Given this list of marker genes MT-ATP6, XPR1, HLA-DQB1, EOGT, NDUFB11, PRKAR1A, XPA, AQP5, BANF1, IL17RA, NR3C1, RIN2, ZNF408 (zinc finger protein 408), CSTA, ERCC6, TBL1XR1, BLOC1S5, C2, BLOC1S3, BTNL2, EPHB4, FIP1L1, ARX, NAGA, CASP10, TGM1, DHCR7, NBEAL2, GNE, HEATR3, ITGB3, PTPN22 (NCBI Gene Id 5779), CREB3L1, LOX, TNFRSF1B, TFR2, TYMS, MT-ND5, HCK, MCFD2, FGG, SMC1A, TNFSF11, SLC39A13, GJA8, ITGB4, FRG1, F8, FANCA, NEU1, ALOXE3, COL1A2, MRAS, GNB2, MBTPS2, PIGW, LZTR1, NABP1, PRF1, HCCS, IL36RN, ANKRD26, PARN, DKC1, TET2, F12, CD28, KRT10, STAT3, ATRX, AGA, TTI1, RAB27A, PDGFB, PPP1R15B, TGM5, WRN, SLC2A10, IL12RB1 (interleukin 12 receptor subunit beta 1), ARL6IP6, STAT5B (signal transducer and activator of transcription 5B), BMS1, AGXT, UNC13D, ORAI1, FOXE3, CBL, MEFV, PEPD, MT-ND2, PIGY (phosphatidylinositol glycan anchor biosynthesis class Y), RTEL1, KIT, GP1BA, CLEC7A, GFI1B, TCF4, SPIB, SMAD2, SH2B3, RASGRP2 (NCBI Gene Id 10235), PLOD3, COL5A2, SDHB, RPS6KA3, HPS4, RNASEH2A, ARVCF, CBS, TPM4, F5, ENG, DIAPH1, NRAS, STX11, PIK3R1, ALDH18A1, MT-TW, RNASEH2C, ARHGAP31, CIB1, CDKN1B, FKBP14, SETX, ADAR, HLA-B, TBK1, PRDM16, SUPT16H, TGFBR1, PRKG1, F13A1, IL7, ALDH3A2, PRKACG, GATA2, POLD1, MRE11 (MRE11 homolog, double strand break repair nuclease), WIPF1, ERCC2, MMEL1, LRP1, MAT2A, GABRD (gamma-aminobutyric acid type A receptor subunit delta), THSD4, ATP7A, STXBP2, KDSR, PEX6, RRAS, FECH, SMC3, IL12A, MT-TS2, MPL, CR2, ADGRE2, RECQL4, PLG, TCIRG1, RARA, KCNAB2, RECQL, SAMHD1, HPS5, F7, XRCC4, FERMT3, NLRP3, PDE11A, COL5A1, ETV6, ENPP1, ADAMTS2, PTPRJ (protein tyrosine phosphatase receptor type J), MASP1, MVK, BMPR2, FANCE, PIGO, DNASE1L3, RERE, MST1, PERP, RNF168, RHOH, IFNG, VPS53 (NCBI Gene Id 55275), DCLRE1B, ETHE1, BCOR, PYCR1, GPR35, RAF1, USP8, NHP2, C1R, NFKB1, WAS, PCNA, ZBTB16 (NCBI Gene Id 8070), NAXD, B3GALT6, BRAF, PGAP2, FUCA1, GP1BB, RRAS2, COG4, CFHR1, DLL4, CHST14, ODC1, F9 (coagulation factor IX), COL1A1, ICOS, FANCC, UBA2, GLUL, RUNX1, CCM2, RAD21, ERCC4, TNFSF15, SLC29A3, PIGV, ARMC5, POLA1, NLRP12, FGB, DSE, FGA, MT-ND4, ITGA2B, ADAM17, HPS3, PML, PTDSS1, NLRC4, AEBP1 (AE binding protein 1), COG8, HLA-DPB1, NUMA1, WNT10A, TMC8, MT-ND1, GJB3, SEC24C, OCLN, LMAN1, HBA1 (NCBI Gene Id 3039), SAMD9, LUZP1, SRSF2, GUCY1A1, USF3, IARS2, CAVIN1, UVSSA, GNA11, HS3ST6, AIP, TSPAN12, LMNA, GJB4, DPP9 (NCBI Gene Id 91039), FAS, LBR, TMC6, ANTXR1, PGM3, HPS1, IRF5, KRT2 (NCBI Gene Id 3849), NDP, TNFSF12, ELN, GLB1, MAP2K1, SOX18, LYST, IKZF1, LSM11, ARID1B, ACP5, F10, HEY2, TGFBR2, ARPC4, HOXA11, STING1 (stimulator of interferon response cGAMP interactor 1), POLR3A (RNA polymerase III subunit A), THBS2, MT-ND6, CFH, POU2AF1, SLURP1, SDHC, SERPINF2, SOS1, MYOF, GJA5, RBPJ, MT-CO1, GLA, RAC2, MTAP, DSP, SLC27A4, LORICRIN, TRPM4, NOD2, FLNA, CDH23, LCP2, TBXA2R, IFIH1, GNAS, KRAS, ZNF469, KIAA0319L, MT-CO2, JAK2 (Janus kinase 2), PRKACA, CARMIL2, POLE, TALDO1, RASA1, SASH1, BMP2, C1QB (NCBI Gene Id 713), CYLD, H4C3, AGPAT2, ATM, CTNNB1, MYH11, STAG1, NBN, PDPN, MYH9, PSMB8, NFIA, KRIT1, ANGPT1, EFEMP1, DOCK6, USP18, IPO8, C1S, SLC25A24, DDX11, VWF, ERCC3 (ERCC excision repair 3, TFIIH core complex helicase subunit), BSCL2, SPRED2, GGCX, HBA2, DPM1, ALOX12B, SCN11A, RNASEH2B, LRP5, TBX1, ATR, TERT, UBE4B, TNFRSF1A, TGFB2, PSMG2, SERPINE1, ACVRL1, NSDHL, PLAU, GP9, SLC37A4, SERPING1, MT-ND4L, ELOVL4, CAV1, PRDM5, POLH, STIM1, GJA1, TAF6, FLT4, GATA1, COL7A1, GNAQ, TNXB (tenascin XB), APOLD1, SLC39A4, WRAP53, MMP23B, MANBA, CASZ1, BRD4, UFD1 (NCBI Gene Id 7353), ANTXR2, PIK3CA (NCBI Gene Id 5290), MT-CO3, MT-TQ, VEGFC, KCNQ2, XPC, AP1S1, IL17F, TNPO3, LMX1B, NPM1, IRF2BP2, EGFR, APOE (NCBI Gene Id 99), XPNPEP2, HIRA, STXBP1, NDUFS2, CPN1, GSN, MYD88, TRAF3IP2, F13B, DDR2, JAM2, KLLN, CTSB, KLK11, SULT2B1, PLOD1, MT-CYB, CCN2, CD109, NF1, NSUN2, IKBKG, PPARG, GIMAP5, PGAP3, RNF213, ATP6V1E1, FCGR2C, SCARB2, ANAPC1, LIG4, MAPK1, COL3A1, SIK3, COX7B, PNKP (polynucleotide kinase 3'-phosphatase), SMAD3, ATP6V0A2, MYLK, PIGL, SPINK5, SOS2, KNG1, SDHD, AKT1, SYK, SEC23B, RREB1, FASLG, FYB1, DDB2, DST, MT-TF, BLM, TNFRSF13B, SLFN14, PROS1, DTNBP1, CD19, SREBF1, GDF2, SLC51A, SEMA4D, FTO, SKI, P2RY12, RASA2 (NCBI Gene Id 5922), HDAC8, TREX1, FBN1, PORCN, ACTA2, LIPN, PTPN11, FOSL2, PDGFRB, PRKCZ, FANCD2, CTSA, LEMD2, TGFB3, TP53, MT-TH, GBA1, ITGA3, CD81, ATP7B, MYORG, GNA14, F2, PLEC, BGN, TRPV3 (transient receptor potential cation channel subfamily V member 3), FOS, ELMO2, KRT83, NFIX, KRT1, ASXL1, PDSS1, NOTCH1, ZMPSTE24, CTC1, PRTN3, SLC20A2, SF3B4, FZD4, ABCC6, C4A, DNAJC30, ABL1, SCN10A, DSG4, IL17RC, GNPTAB, USP48, LIG1, TERC (NCBI Gene Id 7012), RNF113A (NCBI Gene Id 7737), HFE, ATP2C1, RIT1, MT-TL1, EPHB2 (EPH receptor B2), SETD2, HLA-DRB1, CALR, SBDS, HLA-DPA1, MS4A1, FERMT1, LYZ, PLCG1, JMJD1C, NTRK1, GCGR, HPGD, SLC35A1, PDCD10, NIPBL, ABCC9, STN1, RNU7-1, CLCN7 (chloride voltage-gated channel 7), SPEN, ARPC1B, G6PC3, COMT, ADA2, MFAP5 (NCBI Gene Id 8076), KDM1A, LARP7, CTLA4, CCR6, KRT5, NFKB2, HPS6 (NCBI Gene Id 95477), CBLB, CAST (calpastatin), ITGA2, SMAD4, TNFRSF13C, SCN9A, UBAP2L, ERCC5, AKT3, PROC, ATP6V1A, ALPK1, USB1, DBR1, FOXP3, APOA1, EMILIN1, LYN, KRT14, SNX10, PTEN, PLCG2, GP6, TINF2, HSPG2, NOP10, CFHR3, here is a description of the gene set: Human Gene Set: HP_VASCULAR_SKIN_ABNORMALITY studied in species Homo sapiens Vascular skin abnormality